Given this list of marker genes INS, UCN, GHRL, OPRK1, NPSR1, LEPR, GHSR, TTC21B (tetratricopeptide repeat domain 21B), GNB3, AGRP, CFAP20, MC1R, QRFP, MC3R, SLC24A4, NPY, NMU, STAT3, RXFP4, SGIP1, INSL5, GPR171, NAPEPLD, TACR3, RETN, EIF2AK4, NR4A3, NPY2R, MC4R, here is a description of the gene set: Human Gene Set: GOBP_REGULATION_OF_FEEDING_BEHAVIOR studied in species Homo sapiens Any process that modulates the rate, frequency or extent of the behavior associated with the intake of food.